Given this list of marker genes FKBP5, EMP2 (epithelial membrane protein 2), CYP4B1, UQCRFS1, PRR15L, TMT1A, CEACAM20, VXN, ZBTB16, CITED2, RPL7P32, PYGO2, C14orf28, CIDEC, ATP5MJ, NUDT16, ECI1, ETNK2, CISD1, NDUFB4, ACADL, COX6B1, FMO3, KCNB1, SLC41A3, KIAA0040, RDH16, LY6G6D, JPH2, LINC02997, SORBS1, PLAC8, PDE4DIP, SUSD3, KCNJ8, MAOA (NCBI Gene Id 441491), PDE6G, CCDC172, EPHX2, ZNF219, PEBP1, MINDY1, here is a description of the gene set: species: Homo sapiens Human Gene Set: FEKIR_HEPARG_SPHERE_VS_HEPARG_DN Human hepatocellular carcinoma (HCC) heterogeneity promotes recurrence and therapeutic resistance. We recently have demonstrated that inflammation favors hepatocyte retrodifferentiation into progenitor cells. Here, we identified molecular effectors inducing HCC metabolic reprogramming, chemoresistance and invasiveness of retrodifferentiated stem cells. Spheroid cultures of human HepaRG-progenitors (HepaRG-Spheres), HBG-BC2, HepG2 and HuH7 cells and isolation of side population (SP) from HepaRG cells (HepaRG-SP) were followed by transcriptomics, signaling pathway analysis and evaluation of chemotherapies. Gene expression profiles of HepaRG-SP and HepaRG-Spheres were enriched in signatures related to cancer stem cells, metastasis and recurrence and showed that HepaRG-progenitors can further retrodifferentiate into a more immature state. The transcriptome from these stem cells matched that of proliferative bad outcome HCCs in a cohort of 457 patients. These HCC stem cells highly expressed cytokines triggering retrodifferentiation and displayed high migration/invasion potential. Importantly, they showed changes in mitochondrial activity with reduced membrane potential, low ATP production and high lactate production. These changes were in part related to angiopoietin-like 4 (ANGPTL4)-induced upregulation of pyruvate dehydrogenase kinase 4 (PDK4), an inhibitor of mitochondrial pyruvate dehydrogenase. Interestingly, up-regulation of ANGPTL4 and PDK4 paralleled that of stem cells markers in human HCC specimens. Moreover, the PDK4 inhibitor dichloroacetate reversed chemoresistance to sorafenib or cisplatin in HCC stem cells derived from four HCC cell lines. In conclusion, retrodifferentiated cancer cells develop enhanced invasion and therapeutic resistance through ANGPTL4 and PDK4. Restoration of mitochondrial activity in combination with chemotherapy represents an attractive therapeutic approach in HCCs. from publication Fekir K, Dubois-Pot-Schneider H, Désert R, Daniel Y, Glaise D, Rauch C, Morel F, Fromenty B, Musso O, Cabillic F, Corlu A (PMID 30837223) Genes down-regulated in the cancer stem HepaRG-sphere vs HepaRG at 10 days of differentiation